The following is a description of a gene set: Human Gene Set: RP58_01 studied in species Homo sapiens Genes having at least one occurrence of the motif NNAACATCTGGA in the regions spanning 4 kb centered on their transcription starting sites. This matches the ZNF238 transcription factor binding site V$RP58_01 (v7.4 TRANSFAC)., and this is the list of marker genes: GIGYF2, CYRIA, HSPB7, GGCX, HGF, RCOR2, MYL3, NAV1, FGF20, ONECUT2, GFPT2, PRICKLE1, LENG9, SCGN, B3GALT2, GAS7, TSC22D3, PNMA1, WNT2, COL16A1, C1orf116, SCN2B, CLEC14A, LIX1, RUNX1, PHOX2B, C1QTNF1, SLC4A1, POU3F4, CACNG4, ATOH8, PTK7, PCOLCE, FGF7, NUAK1, EYA1, FMNL3, DAPK1, UBTF, S1PR2, ADAMTS2, LRRFIP1, RIMS2, NR3C1, SLC26A7, DMD, ANK2, CNIH2 (cornichon family AMPA receptor auxiliary protein 2), ONECUT1, TGFBR2, FOXP1, PLPP3, KLF13, NR4A2, ASIC1, TP63, CACNA2D3, ZEB2, PRKACA, CALM1, TFAP4, RNF216, ITGA8 (NCBI Gene Id 8516), COLEC12, EGFL6, TP53INP2, CA10, LTBP1, ACVR1, HOXC4, NTRK2, ABLIM3, NKX2-2, ACKR1 (atypical chemokine receptor 1 (Duffy blood group)), PDE10A, PROK2, TBPL1, PTCH2, PHLDB1, TNS1, SLC6A10P, RAB6A, LRRTM3, CDH6, PARP8, LARP4, GLRA1, LMO3, PMF1, PPP4R3C, SIPA1 (NCBI Gene Id 6494), GFRA3, TGFB3, OMA1, XKRX (XK related X-linked), LINC01138, SND1, POU4F1, CREB3L2, LUC7L3, TCF12, SH3GLB2, RAG2, DLX5, ARX, TSKU, ABR, LRRC1, GLT8D2, PDGFB (platelet derived growth factor subunit B), MAGED1, INHA, CD79B, PPM1B, ASIC2, FOXP2, FAM180A, RDH5 (retinol dehydrogenase 5), SRPX2, CABP7, ZBTB18, CACNA1G, LBX1, COL7A1, TAC1, ARL4C, ADAMTS10, DNAJC11, LRRC42, SPTB, SPRED2, DTX2, FGF10, GPSM2, NRGN, DNAJC5B, HOXC12, LINC01597, CCDC26, MOAP1, GRIN2D, S100A10, BTBD3 (BTB domain containing 3), SORBS1, FOXN3, PITX3, CILP, ANP32A, B3GNT9, ATP2A2, PPRC1, DLG3, BLMH, PPP1R9B, TNKS1BP1, KERA, ATOH7, PACRG, UBQLNL, TNFAIP8, PRKN, ERN1, CNPY3, HELZ2, CASC2, EPHA7, LRTM1, DHX30, CMKLR1, NEUROG3, SHOX2 (SHOX homeobox 2), WNT2B, ERG, HOXA3, OLFML1, MRGPRF, PCDH1, LRP5, ARHGAP22, MBNL2, RARG, ADGRB3, ANKRD12, KATNA1, FGF9, KIF21A, TLL1, CDC42EP2, KLF5, NXPH4, ATF3, TLR7, CBFA2T3 (CBFA2/RUNX1 partner transcriptional co-repressor 3), COL3A1, IGF1, NXPH3, WNT9A, TNNI3K, HABP2, SEMA6D, PODN, CNTN2, TNNI2, RBFOX1, TMEM59L, TRIM37, CACNB2, PRG4, SEPTIN3, RBMS1, NTN1, AMD1